Given this list of marker genes NHERF2, PRNP, HOMER3, NHERF1, ADORA2A, HOMER2, CALM3, HOMER1, NECAB2, FYN, here is a description of the gene set: species: Homo sapiens Binding to a G protein-coupled glutamate receptor (a metabotropic glutamate receptor). Human Gene Set: GOMF_G_PROTEIN_COUPLED_GLUTAMATE_RECEPTOR_BINDING